The following is a description of a gene set: Somatic cells can be reprogrammed to a pluripotent state through the ectopic expression of defined transcription factors. Understanding the mechanism and kinetics of this transformation may shed light on the nature of developmental potency and suggest strategies with improved efficiency or safety. Here we report an integrative genomic analysis of reprogramming of mouse fibroblasts and B lymphocytes. Lineage-committed cells show a complex response to the ectopic expression involving induction of genes downstream of individual reprogramming factors. Fully reprogrammed cells show gene expression and epigenetic states that are highly similar to embryonic stem cells. In contrast, stable partially reprogrammed cell lines show reactivation of a distinctive subset of stem-cell-related genes, incomplete repression of lineage-specifying transcription factors, and DNA hypermethylation at pluripotency-related loci. These observations suggest that some cells may become trapped in partially reprogrammed states owing to incomplete repression of transcription factors, and that DNA de-methylation is an inefficient step in the transition to pluripotency. We demonstrate that RNA inhibition of transcription factors can facilitate reprogramming, and that treatment with DNA methyltransferase inhibitors can improve the overall efficiency of the reprogramming process. Mouse Gene Set: MIKKELSEN_IPS_LCP_WITH_H3K27ME3 species: Mus musculus from publication Mikkelsen TS, Hanna J, Zhang X, Ku M, Wernig M, Schorderet P, Bernstein BE, Jaenisch R, Lander ES, Meissner A (PMID 18509334) Genes with low-CpG-density promoters (LCP) bearing the tri-methylation mark at H3K27 (H3K27me3) in MCV8.1 cells (induced pluripotent cells, iPS)., and this is the list of marker genes: Wfikkn2, Slc23a3, Itln1, Prnd, Mylk2, Ugt1a1 (UDP glucuronosyltransferase 1 family, polypeptide A1), Coro6, Cacna1s, Cd244a, Gal3st4, Car15